The following is a description of a gene set: species: Mus musculus Genes predicted to be targets of miRBase v22 microRNA mmu_miR_680 in miRDB v6.0 with MirTarget v4 prediction scores > 80 (high confidence targets). Mouse Gene Set: MIR_680 from publication Chen Y, Wang X (PMID 31504780), and this is the list of marker genes: Pbx2, Chl1, Sarm1, Slc25a53, 2310002L09Rik, D630045J12Rik, Rictor, Rgs9, Sox18, Zfp36l1, Ptp4a1, Proser2, Xirp2, Cyp2d22, Sytl2, Coro2b, Tor1b, Card10, Cacng5, Pamr1, Rab4a, Elavl1, Sidt2, Klhdc10, Ube2k, Slc6a8, Tiam1, Kmt5b, Aldh5a1, Rnf44, Kmt5a, Ghr, Tdrd3, Stx7, Kcnn4, Stx3, Hccs, Arpc5, Gpm6b, Prx, Bsn, Phc3, Scaf8, Mamld1, Pign, Cpeb2, Plac1, Rell1, Tsc1, Plekhg1, Oser1, Smim26, Casp6, Kif13a, Chchd4, Ssbp1, Tbc1d24, Xpo7, Cd164, Tmem183a, Gpc5, Pdcd6, Zdhhc9, Selenoi, Ctdsp2, Crppa, Stc1, Bmpr2, Rwdd4a (NCBI Gene Id 384818), Megf11, Sgms1, Tmprss11g, Popdc3, Garem1